The following is a description of a gene set: Human Gene Set: HP_CYSTIC_LIVER_DISEASE species: Homo sapiens Cystic liver disease, and this is the list of marker genes: LRP5, RPGRIP1L (RPGRIP1 like), TMEM216, IFT140, MKS1, EXTL3, TMEM67, ALG5, TCTN2, SEC63, PKHD1, CC2D2A, IFNG, CEP290, ALG8, RPGRIP1 (RPGR interacting protein 1), TSC1, BICC1, B9D1, TMEM107, PKD2, TCTN3, ALG9, TSC2, NPHP3, CSPP1, PKD1, TXNDC15, TTC21B, TMEM237, DNAJB11, OFD1, JAK1, TCTN1, WDR19, B9D2, TMEM231, NEK8 (NCBI Gene Id 284086), IFT122, GANAB, PRKCSH (NCBI Gene Id 5589)